The following is a description of a gene set: Human Gene Set: REACTOME_RAC2_GTPASE_CYCLE species: Homo sapiens RAC2 GTPase cycle, and this is the list of marker genes: TFRC, DSG2, RACGAP1, ESYT1, DOCK10, GIT1, PAK4, SAMM50, TMPO, ARHGAP17, CYFIP1, TAOK3 (TAO kinase 3), SWAP70, LBR, GARRE1, CAV1, MPP7, ARHGAP39, MCAM, LEMD3, ARHGDIA, SYDE1, ANKLE2, STBD1, VANGL1, WASF2, VAV1, EPHA2, CYBB, MTX1, DOCK1, RAC2, TIAM1, DEF6, OPHN1, PAK1, DEPDC1B, ERBIN, PIK3R2, VAV2, ARHGAP35, PGRMC2, IQGAP1, BRK1, ABI1, ARHGAP26, NCF1, CYBA, LAMTOR1, PIK3R1, PAK2, DOCK4, PREX1, TRIO, NCKAP1, PIK3CA, DOCK2, VRK2, NCF2, DIAPH3, DOCK3, BCR, SLITRK5, VAMP3, CDC42EP4, GIT2, ABI2, VAV3, ITGB1, NCKAP1L, NCF4, PIK3R3, BAIAP2L1, ARHGAP42, ARMCX3, NHS, LMAN1, ARHGAP21, EMD, CDC42EP1, CDC42, ARHGAP1, PLD2, RAB7A, ABR, MCF2, VAPB, ARHGAP32